The following is a description of a gene set: Any process that activates or increases the frequency, rate or extent of addition of phosphate groups to a molecule. studied in species Homo sapiens Human Gene Set: GOBP_POSITIVE_REGULATION_OF_PHOSPHORYLATION, and this is the list of marker genes: CHI3L1, MMP9, TLR3, VEGFA, ERN1, PROM2, DOK7, DIRAS1, NIBAN1, ABI1, SNX9, STOX1, FBN1, CIMAP3, FLT1, S1PR2, NRG1 (neuregulin 1), IL31RA, HES1, ALS2, GLMN, IRGM, THPO, BMP4, ABL1, LIMCH1, CAB39, AKT1, ENPP2, UNC119, PLAUR, RSPO1, THBS4, DRD4, ARHGEF2, TAB2, TNFRSF18, FGF7, FGF1, STRADB, ANGPT1, BRAF, RAF1, PTK2B, SPDYA, PDCD10, TPD52L1, CSF1R, PRKCD, PRLR, TBX1, FGF2, CCNY, XRCC6, STRADA, ANGPT4, DSCAM, APLN, ADIPOQ, IL6, ARAF, PPIA, KIF14, IFNL1, MAP3K5, LCP2, LAT, XRCC5, SPRY2, C3, DYNAP, TRAF4, DDRGK1, PARP14 (NCBI Gene Id 54625), ITLN1, RALBP1, BRAT1, ROCK2, MAP3K7, ELANE, TPX2, TNFSF15, IL20, MMD2, CREBL2, PIK3R5, LEP (leptin), EGF, RASSF2, ZNF16, TRAF6, RIPK1, PIK3CG, PIN1, TENM1, LILRA5 (leukocyte immunoglobulin like receptor A5), KNDC1, EGFR, TCIM (transcriptional and immune response regulator), CACUL1, TGFB1, PFN2, JAK2, PDGFA, CLSPN, FGFR3, RAP1A, RAP2A, LIF, MRNIP, IL18, ERBB4, MAP3K4, ANG, MAPK1, GRB10, CNTF, ADCY8, ADCYAP1, TLR6, CLIP3, DIPK2A, MAP2K1, AGAP2, MAP2K3, NEDD9, ERCC6, MAP2K2, CARD14, FGF19, IL15, ADAM17, FZD7, PIK3R6, ZNF268, PSMD10, ZNF622, GPER1, STK4, AREG, DSTYK, MUSK, LMO4, RIPK2, MT3, ERBB2, CD80, CAMK1, FAM20A, CTF1, LTF, PARP9, ETAA1, PIBF1, MMD, FGFR1, STK11, UBE2K, CIB1, CNOT9, BMP2, ATG14, JTB, COPS8, CRIPTO, PDGFRB (NCBI Gene Id 5159), IL21, RARRES2, CENPE, SDCBP, CEMIP, EEF1A2, SRC, WNT5A, PIM1, WNK3, HMGA2, IFNG, PELI2, KDR, LYN, NEK10, TNFRSF10A, IGF1, BCL10, DDR2, MAP4K2 (NCBI Gene Id 5871), CDKN1A (NCBI Gene Id 1026), CDK2AP1, TNIK, KCTD20, EFNA5 (ephrin A5), EFNA1, RAC1, HDAC3, RALB, OSM, MAD2L2 (NCBI Gene Id 10459), CASS4, SYAP1, PTPN1, SPHK1, SIRT1, FLT3, IL11, IL12A, CARD10, NRP1, RACK1, LACRT, SEMA4D, DHX34, CD4, TNK2, ARRB1 (arrestin beta 1), CSPG4, PTPRC, ACVR2A, ARL2BP, FGF18, MIF, TRIM6, FGF10, KIT, GAS6, TIGAR, PILRB, CCDC88A, CD74, EZH2, HLA-DRB1 (major histocompatibility complex, class II, DR beta 1), BANK1, CALCA, THBS1, TRAF2, VEGFB, NPTN, PDGFB, TNFRSF10B, FAXDC2, PIH1D1, FLT4, WEE2 (NCBI Gene Id 494551), TNF, ITGB1BP1, RIPK3, FLOT1, ECT2, TAOK3, ARHGEF5, GPRC5B, IL34 (NCBI Gene Id 146433), MST1R, TNFSF18, FBH1, ODAM, ZFP91, MYDGF, PTK2, TOM1L1, SASH1 (NCBI Gene Id 387570), XBP1, DIRAS2, EREG, MAP3K10, RAPGEF2, RASGRP1, MAP3K11, S100A12, RHOA, AKTIP, SRCIN1, WDFY2